Given this list of marker genes Pip4k2a, Gsk3b, Irs1, Prkca, Trim72, Prkcd, Prkaa1, Mstn, Gpr21, Pip4k2c, Pip4k2b, Lpl, Prkcz, Ncoa5, Pid1, Pparg, Rbx1, Mir143, Enpp1, Rps6kb1, Slc27a4, Ncl, Prkcq, Ptprf, Appl2, Il1b, Socs1, Fbxw8, Sco1, Inpp5k, Grb10, Tns2, Zfp592, Ptpn2, Gsk3a, Ankrd26, Rela, Kank1 (KN motif and ankyrin repeat domains 1), Blvrb, Socs3, Cul7 (NCBI Gene Id 66515), Ahsg, Nucb2, Grb7, Nck1, Grb14, Rps6kb2, Ptprj, Tsc2 (NCBI Gene Id 22084), Inppl1, Grk2 (G protein-coupled receptor kinase 2), Tnf, Prkcb, Ptpre, Lonp1, here is a description of the gene set: Any process that stops, prevents or reduces the frequency, rate or extent of cellular response to insulin stimulus. Mouse Gene Set: GOBP_NEGATIVE_REGULATION_OF_CELLULAR_RESPONSE_TO_INSULIN_STIMULUS species: Mus musculus